Given this list of marker genes HOXB4, ITPKB, TAP2, HOXB-AS3, HOXA9, MIR4434, HOXA7, LINC01063, HOXB3, MTSS1 (NCBI Gene Id 9788), HCG4B, here is a description of the gene set: Human Gene Set: NUP214_TARGET_GENES from publication Yevshin I, Sharipov R, Kolmykov S, Kondrakhin Y, Kolpakov F (PMID 30445619) Genes containing one or more binding sites for (NUP214) in their promoter regions (TSS -1000,+100 bp) as identified by GTRD version 20.06 ChIP-seq harmonization. species: Homo sapiens